The following is a description of a gene set: Human Gene Set: GOMF_BASAL_TRANSCRIPTION_MACHINERY_BINDING studied in species Homo sapiens Binding to a component of the basal transcription machinery which is composed of the RNA polymerase core enzyme and the basal transcription factor(s), the minimal set of factors required for formation of the preinitiation complex (PIC) by the RNA polymerase., and this is the list of marker genes: ESRRB, CDC73, FOXF2, PCIF1, SCAF4, NCOA3, RECQL5, AGO2, LEO1, BRD4, POLR2M, TP53, PAF1, RPRD1A, SMYD3, SCAF8, NOP58, RPRD1B, ELOF1, GTF2B, WAC, ZNHIT6, ZNF326, RPRD2, CTDP1, SMYD2, SUPT4H1 (SPT4 homolog, DSIF elongation factor subunit), HNRNPU, CTR9, TAF1, UVSSA (NCBI Gene Id 57654), AGO1, PCF11, TBP, URI1, FBL, ESR1, CCAR2, RUVBL2, GTF2A1, GTF2F1, EDF1, TAF7, AHR, GTF2E2, SCAF1, TCF4, ERCC1, ERCC5, WDR43, RUVBL1, ELP2, LLPH, DRAP1, GTF2A2, DHX9 (NCBI Gene Id 3450), ERCC4, RTRAF, AR